Given this list of marker genes CYB5R3, CMTM6, DTYMK, COL6A3, CPSF7, FAM162A, ZNF326, PSENEN, GABRA6, PNMT, PRSS8 (serine protease 8), SLC7A2, SPOP, DOK1, MCAM (melanoma cell adhesion molecule), RASL11B (NCBI Gene Id 79093), DNAJC1, WDR20, AHSG, TNC, CYB561, CYP51A1, TXNIP, EPHA4, UTS2R, FIP1L1, HLA-E, ZBTB37, TOR3A, SLC51A, FAHD1, SYNJ2, ZPR1, RPP21, UNCX, CD2, C19orf12, SGIP1, LRRC8A, PAFAH1B1, DNTT, MAPRE1 (NCBI Gene Id 22919), ECE1, PSMD9, CRP, C9orf85, HOXA9, FGGY, G0S2 (G0/G1 switch 2), TCTA, PIPOX, SERPINA12, TIAM2, DACH1, ZFP42, GHITM, SNAP91, MYH8, FGG, C19orf48P, PTPRR, EPB41L2, MX2, NEDD4L, SNAI2, MED27, TSC2, HLX, GLDC, PGAM2, RACK1, NELFCD, CD36, CRY1, PTPN12, SLC20A1, FDFT1, SELENOH, EMCN, FNDC1, VCL, GDF9, SLC23A1, TGDS, SLC1A4, CHD8, EPHA6 (NCBI Gene Id 647649), SNHG6, SFR1, TANGO2, CTTN, CIB1, UGT8, SULT2B1, NOTCH3, HYOU1, MTMR9, IL1R2, MAK, TTR (transthyretin), MYBPH, IL10, HTR1A, SERPINB2, WASF2, MX1 (MX dynamin like GTPase 1), PRUNE1, SUPV3L1, INO80C, POLE4, CHRNB2, H19, KDM3A, FZD9, PLAC8, PTTG1, S100A6, CCT2, PRG2, RBFOX2, RPS6KA1, SLC23A3, FAM83F (NCBI Gene Id 113828), FOXF1 (NCBI Gene Id 2294), ENSG00000286190, MYO5B, PDX1, EPB41L4B, E2F1, FTL, ACOT2, AXL, CELSR2, TRAK2, ITGB7, MGP, B4GALT3, RNASE1 (NCBI Gene Id 6035), CALB2, NPL (NCBI Gene Id 80896), BLTP3A, KIF1C, CYTIP, CASQ2, PEG10, FABP5, NDUFS4, TMEM70, GATM, SYS1, LHX9, PCMT1, CLDN6, SERPINE2, LCT, TSPAN12, AEBP2, ZNF771, COX14, RNF4, UGDH, IRF8, EFNA1, FHL1, USP5, RAC3, CLU, TCF7, WNT6, PODXL, PTHLH, CRLF3, FLNB, CSF3, ACRV1, FSTL3, WDR1, DVL3, AGXT, PRPH2, POLD4, GTF3C1, PCDHA10, RETREG1, PBDC1, DUSP6, NCF4, COL7A1, CTSS, JAM3, IGFBP1, HK2, PAX1, NDFIP2, RPA2, CCR5, APOC2, OGN, PRRC2A, RSPO2, here is a description of the gene set: Genes down-regulated in CD4 T helper cells Th0: 1h versus 10h. Human Gene Set: GSE43955_1H_VS_10H_ACT_CD4_TCELL_DN studied in species Homo sapiens Despite their enormous importance, the molecular circuits that control the differentiation of Th17 cells remain largely unknown. Recent studies have reconstructed regulatory networks in mammalian cells, but have focused on short-term responses and relied on perturbation approaches that cannot be applied to primary T cells. Here, we develop a systematic strategy – combining transcriptional profiling at high temporal resolution, novel computational algorithms, and innovative nanowire-based tools for performing gene perturbations in primary T cells – to derive and experimentally validate a temporal model of the dynamic regulatory network that controls Th17 differentiation. The network is arranged into two self-reinforcing and mutually antagonistic modules that either suppress or promote Th17 differentiation. The two modules contain 12 novel regulators with no previous implication in Th17 differentiation, which may be essential to maintain the appropriate balance of Th17 and other CD4+ T cell subsets. Overall, our study identifies and validates 39 regulatory factors that are embedded within a comprehensive temporal network and identifies novel drug targets and organizational principles for the differentiation of Th17 cells. from publication Yosef N, Shalek AK, Gaublomme JT, Jin H, Lee Y, Awasthi A, Wu C, Karwacz K, Xiao S, Jorgolli M, Gennert D, Satija R, Shakya A, Lu DY, Trombetta JJ, Pillai MR, Ratcliffe PJ, Coleman ML, Bix M, Tantin D, Park H, Kuchroo VK, Regev A (PMID 23467089)